The following is a description of a gene set: Human Gene Set: ZHONG_PFC_C4_PTGDS_POS_OPC studied in species Homo sapiens from publication Zhong S, Zhang S, Fan X, Wu Q, Yan L, Dong J, Zhang H, Li L, Sun L, Pan N, Xu X, Tang F, Zhang J, Qiao J, Wang X (PMID 29539641), and this is the list of marker genes: GNAI1, GPR17, CENPJ, PRDX1, TM9SF2, ZNF488, EVI2A, SEL1L, ARV1, APCDD1, SCARB2 (NCBI Gene Id 950), FIBIN, APPL2, GRINA, TNS3, PCDH7, SYNDIG1, NOL4L, MOB3B, TNS2, ERBB3, OSBPL9, LIN7C, SERPINI1, ACLY, PCDH11Y, RICTOR (NCBI Gene Id 253260), MTPAP, MAP4K5, TMEM59, RND2, PCDH11X, BCL2L1, STAMBP, CADM1, ANK3, TF, LINC02367, MTMR9LP, BPHL, KIAA0319L, HACL1 (2-hydroxyacyl-CoA lyase 1), EEIG1, BMPER, GOLIM4, PLEKHB1, RGMB, CRB1, MSMO1, SGPL1, TMOD1, SLC44A1, ZNF827, CADM2, RASGEF1B, PTPRO, MYRF, MYO5A, LRRN3, TMEM108, MOG, TCF7L2, ITPR2 (NCBI Gene Id 3709), PLPPR2, MMUT, TMEM179B, DYNLL1, SLC25A5 (NCBI Gene Id 292), TNFRSF21, MVB12B, CPM, CORO1C, UGT8, FXYD6, PKP4, SIRT2 (sirtuin 2), TMEFF2, FRMD4A, SNX22, SGTA, ANGPTL2, PFN2, HMGCS1, SERINC5, DHCR7, LINC01170, TM7SF3, PACC1, CLDN11, FYN, LRRTM1, SILC1, TMTC4, NFE2L2, FRMD4B, GRIN2A, TUBB4A, GPS1, PLEKHA1, STRN, GPD1 (glycerol-3-phosphate dehydrogenase 1), NTM, MIEF1, PLP1, HID1, PPP1R16B, KCNS3, PHACTR3, TSC22D4, ENPP6, LIMS2, MPZL1, NFASC, UTP14C, STAT2, MBP, BCAS1, CNP, RNF144A, SMOC1 (NCBI Gene Id 64093), CAMSAP2, SGK1, APLP1, TECR, ADAM23, ARHGAP5-AS1, EPHB1, WASF1, SH3YL1, ANKRD44, SCARB1, FAM13C, LSAMP, CDK18, ARHGAP5, REEP3, PTGDS, RNF216, RAB33A, KANK1, SYNGR2, RALGPS2, EPB41L2, SEMA4D, ANP32B, AARS1, MAG